The following is a description of a gene set: The change in morphology and behavior of a dendritic cell resulting from exposure to a cytokine, chemokine, cellular ligand, or soluble factor. Human Gene Set: GOBP_MYELOID_DENDRITIC_CELL_ACTIVATION species: Homo sapiens, and this is the list of marker genes: STARD7, PYCARD, NOTCH2, UBD, CD2, PSEN1, IL4, SPI1, BATF, IL10, CD37, ITGB8, TRAF6, TGFB1 (transforming growth factor beta 1), SLAMF1, BATF3, RBPJ, HMGB1, CAMK4, HAVCR2, DHRS2, RELB, LTBR, TGFBR2, CSF2, DOCK2, ITGB6, CLEC4D, IRF4, BATF2, TSPAN32, DCSTAMP